The following is a description of a gene set: Human Gene Set: GOCC_MAIN_AXON studied in species Homo sapiens The main axonal trunk, as opposed to the collaterals; i.e., excluding collaterals, terminal, spines, or dendrites., and this is the list of marker genes: TUBB4A, DLG1, CLDN5, KCNQ2, KCNAB1, NRCAM (neuronal cell adhesion molecule), MBP, THY1, SPOCK1, ROBO2, CNTN2, ADORA2A, APP, SCN2B, C9orf72, MYO1D (myosin ID), MAP2, IQCJ-SCHIP1, NAV1, KCNC1, CD40, EPB41L3, DAG1, SPTBN4, KCNA4, KCNA2 (potassium voltage-gated channel subfamily A member 2), LRRC7, MYOC, PARD3, TRIM46, MAP1A (microtubule associated protein 1A), KCNQ3, SCN2A, LGI3, KCNK2, CRH, KCNC2, ADORA1, SCN8A, CNTNAP1, MAP1B, NFASC (NCBI Gene Id 23114), DLG2, UCN, DAGLA, BIN1, HAPLN2, SIRT2, CNGA3, ERMN, LGI1 (leucine rich glioma inactivated 1), SPTBN1, SCN1A, SLC1A2, SCN9A, NCMAP, SCN1B, CNTNAP2, KCNAB2, MAPT, CLCN2, ANK3, KCNK4, KCNA1, UCN3, GABBR1, DLG4, ANK1, MAG, CRHBP